The following is a description of a gene set: Human Gene Set: WP_BIOSYNTHESIS_AND_REGENERATION_OF_TETRAHYDROBIOPTERIN_AND_CATABOLISM_OF_PHENYLALANINE Biosynthesis and regeneration of tetrahydrobiopterin and catabolism of phenylalanine species: Homo sapiens, and this is the list of marker genes: SPR, MAOB, COMT, PTS, ASMT, PNMT, GCH1, MAOA, DNAJC12, DBH, QDPR, TH, DHFR, AANAT, PAH